The following is a description of a gene set: Genes down-regulated in comparison of healthy CD4 T cells versus healthy myeloid cells. studied in species Homo sapiens from publication Hutcheson J, Scatizzi JC, Siddiqui AM, Haines GK 3rd, Wu T, Li QZ, Davis LS, Mohan C, Perlman H (PMID 18275831) Gene expression profile studies have identified an interferon signature in whole blood or mononuclear cell samples from patients with systemic lupus erythematosus. This study was designed to determine whether specific lymphocyte and myeloid subsets freshly isolated from the blood of systemic lupus erythematosus patients demonstrated unique gene expression profiles compared to subsets isolated from healthy controls. Human Gene Set: GSE10325_CD4_TCELL_VS_MYELOID_DN, and this is the list of marker genes: YBX3, FAM110B, NUDT3, WARS1 (tryptophanyl-tRNA synthetase 1), BASP1, CYP1B1, HSPA6, IL13RA1, SLC16A3, RXRA, APLP2, NOTCH2, GFOD1, FCGR2A, TRAK1, QPRT, RHOQ, P2RY13, CCDC88A, SIRPA, STX7, RIN2, RNPEP, CDK2AP1, SIDT2 (NCBI Gene Id 51092), NFE2, TESC, RGS2, IFNGR2, TNFSF13, RUSC2, LY86, IFI30, CLEC7A, TLR6, BTK, SLC11A1, MEF2C, NCF4, ITGAM, TUBB6, ORAI3, FCGR1BP, MEGF9, HLA-DQB2, DENND3, SLC31A2, CD86, CEBPB, IRF8 (NCBI Gene Id 3394), HLA-DQB1, CORO1C, SCPEP1, NPL, HEXB, ITGAX, LILRB3, BCL6, SKAP2, SYK, REPS2, TMT1A, OSBPL11, CTNNA1, ENC1, CTBP2, UPK3A, LHFPL2, DSE, RNASE6, KCNMB1 (potassium calcium-activated channel subfamily M regulatory beta subunit 1), P2RX1, GRK3, NFKBIE, RNF141, MTMR11, TRIB1, CTSH, NCF1C, FTH1P5, LMO2, SLC6A12, EAF2, FAM114A1, SNX10, HLA-DRB6, FGR, CDKN1C, DYSF, GM2A, CD1D, LAT2, PLEKHO1, TBC1D9, GAB2, ALOX5, COL9A2, CDKN1A, HLA-DRB1, TSPAN4, ADM, CSF1R, MTMR14, CARD9, PRKCD, SLC43A3, CXCR2, CLIC4, SLC15A3, CHST15, HLA-DPB1, CLPB, CYBB, SAT1, PLEK (pleckstrin), MSR1, LILRA2, LYN, CLCN5, PHC2, PEA15, HTRA1, SCRN1, ATP6V0A1, NCOA4, ADGRE2, SLC2A6, ZDHHC7, SERPINF1, NREP, SLC17A9, ALDH2, RAB5IF, LTA4H, IRF5 (NCBI Gene Id 84729), OAZ2, HCK, THEMIS2, MAP2K3, LYL1, ACTG1, SCARB1, EPB41L4A-DT, CSF2RB, HLA-DMA, SLC7A7, CCR1, MARCKS, MARCHF1, TLR5, SPINT1, CD1C, PSEN2, ENTPD1, RAB31, ADORA2B, SNX27, DHRS9, KMO, VNN1, RHBDF2, CYRIA, RBM47 (NCBI Gene Id 54502), RAB32, HHEX, PTGS1, GSN, PADI2, RPH3A, IL22RA1, ROGDI, HLA-DMB, GCNT1, ATP10D, NAGK, PLCG2, LRP1, TNS3, MYD88, ANXA4, PRCP, FIG4 (FIG4 phosphoinositide 5-phosphatase), OPN3, HSBP1, FGL2, CBFA2T3, VENTX, ICAM1, HLA-DPA1, ZSCAN9, PLXNC1, HMGB3, AQP9, SH3BP2, LYST (lysosomal trafficking regulator), SUOX, KYNU, PLAUR, TLR7, DGKG